The following is a description of a gene set: studied in species Mus musculus Any process in an organism that results in the killing of cells of another organism, including in some cases the death of the other organism. Killing here refers to the induction of death in one cell by another cell, not cell-autonomous death due to internal or other environmental conditions. Mouse Gene Set: GOBP_KILLING_OF_CELLS_OF_ANOTHER_ORGANISM, and this is the list of marker genes: F2, Ppbp, Cxcl12, Pomc, Ccl27a, Ccl1, Ccl21e, Hamp2, Ccl19-ps5, Ccl20, H2bc12, Romo1, Cxcl14, Cst11 (cystatin 11), Gm12250, Camp, Kng2, Ccl21f, Gapdhrt2, Cxcl11, Cxcl13, H2bc21, Ccl17, Gapdhrt, Defb21, Gzmd, Syk, Ccl21d, Gzma, Lyz1, Hrg, Pglyrp1, Gzmg, Spag11b, Myd88, Hamp, C8b, Ifng, Igtp, C9, Lgals3, Ninj1, Pglyrp4, Arg1, Scnn1b, Trem3, Mbl2, Lyz2, Ccl21a, Cxcl1, C8g, Cxcl10, Ccl27al, C8a, Ccl19, Ltf, Ccl22, Ccl19-ps3, Mbl1, Ccl19-ps1, Pla2g2a (NCBI Gene Id 18780), Hmgn2, Lyzl6, Ccl19-ps4, Defb20, Gbp2b, Prf1, Bad, Gzmf, Ctsg, Fcer2a, Gbp7, Cxcl5, Gbp2, Gapdh (glyceraldehyde-3-phosphate dehydrogenase), Apol11a, Tusc2, Nppb, Tac1 (NCBI Gene Id 68182), Fgl2, Nts, Gbp5, Elane, Ccl21b, Cxcl9, Pglyrp3, Ncf1, Irgm2, Ccl28, Trem1, Ccl8, Lyz3, Gzmb, Ccl25, Gbp3, Ccl11, Gzmc, Bcl2l11, Rps19, Gzme, Defa20, Nlrp6, Gapdh-ps15, Ccl27b, Hmgn2-ps, Rpl30, Clec7a, Kng1, Pcyox1l, F2rl1, Dao, Nkg7, Ccl19-ps6, Hc (hemolytic complement), Nos2